Given this list of marker genes JAG1, ROBO2, ADAMTS5, RBPJ, ROBO1, NOTCH2, SLIT2, HEY2, BMP4, TNFRSF1A, TNFRSF1B, GJA5, NOTCH1, STRA6, TBX20, TGFB2, SMAD6, SMAD2, BMPR2, ADAMTS19, HEYL, NOS3, HEY1, NFATC1, here is a description of the gene set: studied in species Homo sapiens Human Gene Set: GOBP_PULMONARY_VALVE_DEVELOPMENT The progression of the pulmonary valve over time, from its formation to the mature structure.